Given this list of marker genes WDR5, NOL4, DLL4, WNT5A, RNASE11, RAX (NCBI Gene Id 30062), TMX1, FBN1, SLC29A1, SPIN4, WDR91, KCNAB1, C12orf60, CA12, IRX1, TRIM16, ISLR2, TOMM20L, ERI2, CATIP, ERBB4, ZNF438, GSX2, TAF7, SOX12, DNAJC22, NRXN3, PAX2, ILK, EML2, EN2, OTOP3, FAM171A1 (NCBI Gene Id 90061), HPS4, FEZF2 (NCBI Gene Id 94016), AFG1L, CDH6, WNT1, IREB2, REXO5, COL14A1, TCF3 (transcription factor 3), UQCRQ, CRABP1 (cellular retinoic acid binding protein 1), SNAP25, STIP1, PTPA, CCDC38, SLC1A2, MARK1, FAM199X, ALCAM, ELMO1, USP48, HOXC5, BLTP1, CSMD3, LMX1A, UTP11, ST8SIA1, HNF1B, HELT, ALOX15, WBP11, CADM1, RASGRP1, GRIA4, LIMCH1, IGF2BP1, NFATC4, SAMD11, HPSE2, RARB, LEF1, RHBG (Rh family B glycoprotein), LINC00273 (NCBI Gene Id 649159), IRX4, SMCHD1, IRX3, KDM1A, ZNF256, HOXD11, TBX5, ISCA1, RGMA, ZNF516-DT, TBX2, XYLT1, MAPT, CR2, TRIM36, FGF10, EBPL, CBY1, NPY1R, ZNF516, NKX2-3, here is a description of the gene set: from publication Kondo Y, Shen L, Cheng AS, Ahmed S, Boumber Y, Charo C, Yamochi T, Urano T, Furukawa K, Kwabi-Addo B, Gold DL, Sekido Y, Huang TH, Issa JP (PMID 18488029) Genes with high histone H3 trimethylation mark at K27 (H3K27me3) in PC3 cells (prostate cancer) by ChIP-chip assay on a 12K CpG array (high-CpG-density promoters, HCP). Epigenetic silencing in cancer cells is mediated by at least two distinct histone modifications, polycomb-based histone H3 lysine 27 trimethylation (H3K27triM) and H3K9 dimethylation. The relationship between DNA hypermethylation and these histone modifications is not completely understood. Using chromatin immunoprecipitation microarrays (ChIP-chip) in prostate cancer cells compared to normal prostate, we found that up to 5% of promoters (16% CpG islands and 84% non-CpG islands) were enriched with H3K27triM. These genes were silenced specifically in prostate cancer, and those CpG islands affected showed low levels of DNA methylation. Downregulation of the EZH2 histone methyltransferase restored expression of the H3K27triM target genes alone or in synergy with histone deacetylase inhibition, without affecting promoter DNA methylation, and with no effect on the expression of genes silenced by DNA hypermethylation. These data establish EZH2-mediated H3K27triM as a mechanism of tumor-suppressor gene silencing in cancer that is potentially independent of promoter DNA methylation. Human Gene Set: KONDO_PROSTATE_CANCER_HCP_WITH_H3K27ME3 species: Homo sapiens